The following is a description of a gene set: Human Gene Set: GOCC_9PLUS0_MOTILE_CILIUM species: Homo sapiens A motile cilium where the axoneme has a ring of nine outer microtubule doublets but no central microtubules (and is therefore called a 9+0 axoneme)., and this is the list of marker genes: CFAP45, DNAH5, ODAD4, DNAH11, ENKUR